The following is a description of a gene set: Genes predicted to be targets of miRBase v22 microRNA hsa-miR-496 in miRDB v6.0 with MirTarget v4 prediction scores > 80 (high confidence targets). from publication Chen Y, Wang X (PMID 31504780) Human Gene Set: MIR496 studied in species Homo sapiens, and this is the list of marker genes: TBC1D12, HNRNPH1, MTHFS, PAX6, GRAMD2B, RASGRP3, LINC03103, CTLA4, CDK1, TYW1B, NR2C1, SEC23IP, FAT4, FYB2, DLX2, PPP6C, ANKRD12, CCDC43, CLUL1, DMXL1, EDIL3, ASCC1, SUMO1, LIMCH1, ANO6, HACD4, PXT1, DACT2 (dishevelled binding antagonist of beta catenin 2), DOCK9, SLC16A14, SGIP1, MCTP1, ELP3, CALB1, VSIG1, MTARC2, TMEM255A, PRSS35, CPEB3, IL33, TXNDC9, DNM1, PHYHIPL, PRKACB, KCMF1, MGAT2 (alpha-1,6-mannosyl-glycoprotein 2-beta-N-acetylglucosaminyltransferase), NPAS3, TMPRSS4, CCNT2, EML4, RBP3, ST20-MTHFS (NCBI Gene Id 100528021), TMCC1, TMEFF2, ASXL2, HIVEP2, RGS18, AMD1, ZNF41, PSMD10, TYW1, RHPN2, MBNL1, ZMYM4, IRF2BP2, PRKD1, CYBB, MTX3, MOXD1, CCDC169-SOHLH2, ITPRID1, ZNF140, PLCG2, FGL1, ILF2, COL9A1 (NCBI Gene Id 1297), MAN1A2, WASHC4, FBXO22, SUV39H2, SEPHS1, BZW2, GARNL3, GFRAL, MRO, MATN3 (matrilin 3), SCN3A, ITCH, SMC1B, GET1-SH3BGR, IFT52 (intraflagellar transport 52), SOHLH2, IPO11, PRMT9, MAP3K2, GPRIN3, FAM185A, QKI, SH3BGR, ZNF202, ZNF136, RIPOR2, ATP2A2, CS, SLC12A2, RANBP9, NXPE4, ALB, PLSCR1, ATOSA